The following is a description of a gene set: part of: MITF-M-dependent gene expression MITF contributes to cellular energetics by regulating the expression of genes such as PPARGC1A, a regulator of mitochondrial biogenesis. MITF-dependent PPARGC1A expression shifts cells towards oxidative phosphorylation. MITF also promotes the expression of SIRT1, an NAD-dependent deacetylase that acts as a rheostat for cellular energetics. SIRT1 contributes to proliferation and inhibition of senescence in part through its regulation of p300. Reactome Pathway: Regulation of MITF-M dependent genes involved in metabolism species: Homo sapiens, and this is the list of marker genes: SIRT1, MITF, PPARGC1A